Given this list of marker genes IKBKG (inhibitor of nuclear factor kappa B kinase regulatory subunit gamma), CHUK, NFKB1, TRAF2, TNFRSF14 (NCBI Gene Id 93208), NFKBIA, TRAF5, TNFSF14, IKBKB, RELA, here is a description of the gene set: Human Gene Set: KEGG_MEDICUS_REFERENCE_LIGHT_HVEM_NFKB_SIGNALING_PATHWAY Pathway Definition from KEGG: TNFSF14 -> TNFRSF14 -> TRAF2/5 -> IKK -> NFKBIA -> NFKB studied in species Homo sapiens LIGHT-HVEM-NFKB signaling pathway. Pathway ID: N00559. Pathway type: Reference. Pathway class: nt06516 TNF signaling.